The following is a description of a gene set: species: Mus musculus Mouse Gene Set: REACTOME_MUSCARINIC_ACETYLCHOLINE_RECEPTORS Muscarinic acetylcholine receptors, and this is the list of marker genes: Chrm3, Chrm2, Chrm5, Chrm1, Chrm4